Given this list of marker genes ETS1, ARF6, PTPN2, SOS1, PAK2, NUMB, GAB2, MAPK3, MTOR, CDC42, RAP1B, SH3KBP1, PARD6A, RPTOR, GRB2, SHC1, MAP2K2, NCK2, RAF1 (NCBI Gene Id 5894), CRKL, F2RL2, RAP1A, APC, PRKCI, RHOA, PLCG1, PTPN1, PTK2, BAD, ARHGEF4, RAB5A, PAK1, CTNNB1, KPNB1, PIK3CA, AKT1, CTNNA1, PXN, RAC1, PTPN11, AKT1S1, NCK1, RANBP9, MUC20, CRK, MAPK8, MET, EIF4EBP1, MAP2K4, HGF, INPPL1, RAPGEF1, PTPRJ, GAB1, CBL, CDH1 (NCBI Gene Id 999), RANBP10, PRKCZ, EGR1 (early growth response 1), SRC, MAP3K1, JUN, SH3GL2, MAP2K1, PIK3R1, PDPK1, MAPK1, EIF4E, MLST8, HRAS, BCAR1 (NCBI Gene Id 9564), AKT2, WASL, SNAI1, RIN2, HGS, DEPTOR, EPS15, PAK4, here is a description of the gene set: studied in species Homo sapiens Signaling events mediated by Hepatocyte Growth Factor Receptor (c-Met) Human Gene Set: PID_MET_PATHWAY from publication Schaefer CF, Anthony K, Krupa S, Buchoff J, Day M, Hannay T, Buetow KH (PMID 18832364)